The following is a description of a gene set: Genes up-regulated in CD4 T cells: NRAS knockout versus wildtype. It has been recently shown that N-ras plays a preferential role in immune cell development and function; specifically: N-ras, but not H-ras or K-ras, could be activated at and signal from the Golgi membrane of immune cells following a low level TCR stimulus. The goal of our studies was to test the hypothesis that N-ras and H-ras played distinct roles in immune cells at the level of the transcriptome. First, we showed via mRNA expression profiling that there were over four hundred genes that were uniquely differentially regulated either by N-ras or H-ras, which provided strong evidence in favor of the hypothesis that N-ras and H-ras have distinct functions in immune cells. We next characterized the genes that were differentially regulated by N-ras in T cells following a low-level TCR stimulus. Of the large pool of candidate genes that were differentially regulated by N-ras downstream of TCR ligation, four genes were verified in qRT-PCR-based validation experiments as being differentially regulated by N-ras (Dntt, Slc9a6, Chst1, and Lars2). Finally, although there was little overlap between individual genes that were regulated by N-ras in unstimulated thymocytes and stimulated CD4+ T-cells, there was a nearly complete correspondence between the signaling pathways that were regulated by N-ras in these two immune cell types. Since we were interested primarily in genes that were differentially regulated by N-ras following a low-level TCR stimulus, our microarray data comparison was between data from TCR-stimulated, WT CD4+ T-cells and from TCR-stimulated, N-ras KO CD4+ T-cells. Genes that were differentially regulated in the comparison between stimulated N-ras KO CD4+ T-cells and unstimulated N-ras KO CD4+ T-cells, as well as those genes that were differentially regulated in the comparison between stimulated WT CD4+ T-cells and unstimulated WT CD4+ T-cells were excluded from this analysis. To determine if N-ras and H-ras regulate different sets of genes in thymocytes, a comparison was made between the set of genes that were differentially regulated by N-ras in the vs. comparison and the set of genes that were differentially regulated by H-ras in the vs. comparison. Human Gene Set: GSE45739_NRAS_KO_VS_WT_UNSTIM_CD4_TCELL_UP from publication Lynch SJ, Zavadil J, Pellicer A (PMID 23755101) studied in species Homo sapiens, and this is the list of marker genes: GSPT1, POLR1E, MSH2, NME1, IFNGR1, EIF3B, AUNIP, BCCIP, SAMSN1, POLR3K, MRPS6, TES, SERPINB9, IPO4, SIK1, NCEH1, TOX, DUSP7, RNF144A, CD48, UMPS, PTGS2, OR13C4, DCAF13, HRH1, TMEM70, TLCD1, GINS3, THUMPD3, DDX28, MMD, SRFBP1, ANKRD37, C2CD2L, SNORD104, UTP18, QTRT2, PITPNA, PITPNB, SNHG4, LTV1, POLR1G, TMEM97, GATAD2A, LONRF3, GPR157, EIF2S1, NCL, GAR1, SLC1A5, PLK3, GALNT4, AQP9, UBIAD1, TASOR2, NKD2 (NCBI Gene Id 85409), MCRIP2, MCM10, SDF4, TOMM5, MB21D2, DUSP2, TNFSF10, STAT4, ENOPH1, ALG3, HJURP, ETV5, KLHL21, FARSA, GOLPH3, SLC5A6, SNHG1, GALNT18, IMP3, RSL1D1, KLF2, EIF2S2, SNRPB2 (NCBI Gene Id 6629), TRNT1, ENSG00000254531, WDR77, USP1, TEX10, ICAM2, RBM18, TFAM, STX11, SPHK1, BCL2, UCK2, NSMF, DLX2, IL10RA, GFOD2, MTHFD1L, RPS6KA5, CHRNA5, RAP1B, NUDCD1, MRTO4, TUBB4B, UBE2G2, MAPKAPK3, NPM3, DNAJA3, SRSF7, NCAPH2, SRPRB, ERICH1, PAICS (phosphoribosylaminoimidazole carboxylase and phosphoribosylaminoimidazolesuccinocarboxamide synthase), PUM3, BCL2L1, TNFRSF25, PSMD11, SH2B3, GPATCH4, DDX47, POLE2, ARHGAP45, GFM1, MRPL41, HNRNPF, DIMT1, PDE9A, NUDC, ELAVL2, MFNG, NDUFAF2, IL2RB, ZNF584, SLC2A1, FAM177A1, TRIB1, C6orf58, ATAD2 (ATPase family AAA domain containing 2), YWHAG, PFKFB3, CDC6, MAPK6, IFNG, TIMM17A, CD55, TWNK, ZEB1, MYO19, PTGER3 (NCBI Gene Id 5733), U2AF1, NFKBIZ, BLOC1S4, ZMPSTE24, DRG1, JPT2, MTRR, NOC3L, LARP4, ISG20L2, DNAJA1, SDE2, COPRS, TIPIN, CNBP, CSF2, FAM241A (family with sequence similarity 241 member A), UTP3, PPAT, NIFK, KLF6 (KLF transcription factor 6), RAD1, ITPR3, MRPL39, TXLNG, NETO2, GPSM1 (G protein signaling modulator 1), BATF3, PEA15, ATG101, PNP, LRFN4, RRAS2, PLD6, NR4A3, NMD3, DDX39A, TMEM158, SLC2A3, TNFRSF12A, PDSS1, OPRM1, CDC123, LRP8, GGCT, E2F6, FAM111B, NAB2, ALG8, JAKMIP1, SNHG17, RAB8B